The following is a description of a gene set: Vocalisation behavior that is the result of learning, or the process by which new vocalizations are learned. Human Gene Set: GOBP_LEARNED_VOCALIZATION_BEHAVIOR_OR_VOCAL_LEARNING species: Homo sapiens, and this is the list of marker genes: SHANK3, DCANP1, TIFAB, STRA6, CNTNAP2, KIAA0319 (NCBI Gene Id 9856), NEUROG1, FOXP2, NRXN2, NRXN1, HTT